The following is a description of a gene set: species: Homo sapiens Human Gene Set: GOBP_POSITIVE_REGULATION_OF_RECEPTOR_CATABOLIC_PROCESS Any process that activates or increases the frequency, rate or extent of receptor catabolic process., and this is the list of marker genes: DTX3L, HAMP, APOE, ABCA2, PCSK9, ITCH, PTPN1, GIT1, LAPTM5